The following is a description of a gene set: from publication Fan X, Dong J, Zhong S, Wei Y, Wu Q, Yan L, Yong J, Sun L, Wang X, Zhao Y, Wang W, Yan J, Wang X, Qiao J, Tang F (PMID 29867213) Human Gene Set: FAN_EMBRYONIC_CTX_IN_5_INTERNEURON studied in species Homo sapiens, and this is the list of marker genes: DLX5, CNR1, DLX6-AS1, SCGN, DLX1, CALB2